Given this list of marker genes Prim1, Gmnn, Mcm10, Orc1, Wrnip1, Mcm2, Ticrr, Cdt1, Topbp1, Orc4, Ciz1, Ccne2, Orc2, Gins3, Prim2, Kat7, Mcidas, Pola1, Cdk2, Mcm4, Mcm7, Gmnc, Rny3, Mcm6, Cdc6, Orc5 (origin recognition complex, subunit 5), Rny1, Pola2, Mcm3, Noc3l, Mcm5, Orc3, Cdc45, Ccne1 (cyclin E1), Orc6, here is a description of the gene set: The process in which DNA-dependent DNA replication is started; it begins when specific sequences, known as origins of replication, are recognized and bound by the origin recognition complex, followed by DNA unwinding. species: Mus musculus Mouse Gene Set: GOBP_DNA_REPLICATION_INITIATION